Given this list of marker genes Gata3, Dbh, Epas1, Kl, Moxd2, Moxd1, Insm1 (NCBI Gene Id 53626), Atp7a, Th, Hand2, here is a description of the gene set: The chemical reactions and pathways resulting in the formation of norepinephrine, a hormone secreted by the adrenal medulla, and a neurotransmitter in the sympathetic peripheral nervous system and in some tracts in the central nervous system. It is also the demethylated biosynthetic precursor of epinephrine. studied in species Mus musculus Mouse Gene Set: GOBP_NOREPINEPHRINE_BIOSYNTHETIC_PROCESS